The following is a description of a gene set: Human Gene Set: BUSSLINGER_GASTRIC_NECK_CELLS from publication Busslinger GA, Weusten BLA, Bogte A, Begthel H, Brosens LAA, Clevers H (PMID 33691112) species: Homo sapiens, and this is the list of marker genes: RGMB, A4GNT, HDLBP, GOLM1, EGR1, FMOD (NCBI Gene Id 2331), SLC12A2, PIK3C2G, NOP53, MSMB, NR4A1, ETV5, COL11A2, CREB3L1, PPP1R1B, AQP5, LYZ, MUC6, GP2, DYNC2H1, CD24, ERGIC1, PDIA2, FUT9, RRBP1, PGC, KCNN4, ERN2, PIGR, SLC4A4, C16orf89, C6orf58, MMP1, TFF2, CST3, CLU (NCBI Gene Id 1191)